Given this list of marker genes Psmd8, Pik3ca, Cd4, Cd101, Psmb1, Pag1, Psma6, Psmb6, Cd3e, Uba52, Pik3cb, Trav19, Ikbkg (NCBI Gene Id 76324), Cd3d, Card11, Ube2d1, Psmc2, Psma5, Trbv16, Psmd7, Psmd11, Psmc4, Adrm1, Inpp5d, Psmb5, Ubc, Pik3r1, Zap70, Lck, Ube2d2a, Chuk, Fbxw11, Cdc34, Psma4, Ube2v1, Nck1, Ube2n, H2-Ab1, Psmd1, Psmd6, Skp1, Psmb3, Ptprj, Malt1, Fyb1, Uba52rt, Cd247, Psmc6, Trac, Psmc5, Rela, Traf6, Nfkb1, Ubb, Bcl10, Grap2, Pak1, H2-Eb2, Ptprc, Pak2, Psmd3, Rps27a, Psmd2, Psmc1, Plcg2, Lcp2, Psmc3, Ikbkb, Psmd13, Plcg1, Nfkbia, H2-Eb1, Psmd14 (NCBI Gene Id 98839), Psma7, Cul1, Tab2, Psmb7, Trav16, Psmb2, Ripk2, H2-Ea, H2-Aa, Csk, Psmd12, Pten (NCBI Gene Id 70161), Trat1, Itk, Cd3g, Ptpn22, Psma2 (NCBI Gene Id 19166), Pdpk1, Trbv15, Psmb4, Psma3, Psma1, Lat (NCBI Gene Id 16797), Prkcq, Pik3r2 (phosphoinositide-3-kinase regulatory subunit 2), Map3k7, Pak3, here is a description of the gene set: Mouse Gene Set: REACTOME_TCR_SIGNALING TCR signaling species: Mus musculus